The following is a description of a gene set: Mouse Gene Set: GOCC_CUL7_RING_UBIQUITIN_LIGASE_COMPLEX studied in species Mus musculus A ubiquitin ligase complex in which a cullin from the Cul7 subfamily and a RING domain protein form the catalytic core; substrate specificity is conferred by a Skp1 linker and an F-box protein., and this is the list of marker genes: Fbxw8, Rbx1-ps, Rbx1, Skp1, Cul7